Given this list of marker genes AZIN1, BICRAL, TDRD6, NHERF2, GRIA4, SNCA, MED27, PURG, KIAA0040 (NCBI Gene Id 9674), CBFB, RFX7, RBBP5, ZNF770, TMEM242, CPEB3, ABI3BP, PCDHB5, C18orf63, CRISP1, RYR2 (NCBI Gene Id 6262), DCUN1D4, PABPC1, CHD6, ODF4, CUL3, PISD, SLC17A6 (NCBI Gene Id 57084), SLC39A10, HSPA8, ARPC5, OMD, PLD1, CMPK1, GRID2, MAN2A1, CLDN23, CADPS, MEF2C, PTH, KLHL1, ADAM10, PCDH10, NDNF, CCAR1, AGTPBP1 (NCBI Gene Id 23287), SPHKAP, ZNF382, CAPZA2, KPNB1, STYX (NCBI Gene Id 730432), CPEB2, TNKS, SOD2, PDE4DIP, MEIS1, CARHSP1, GRK5, HMGB1, FSTL5, KIAA1328, PEX2, OCRL, HIPK1, USP9Y, KCNQ5, DMXL1, PCK1 (NCBI Gene Id 5105), ZSCAN31, UBR1, IGF2BP1, ZNF600, LPAR1, RWDD2A, STX11, CADM2, RAI1, C1orf21, PCDH15, DIP2A, BAALC, EPC2, ZSCAN2, TMEM50B, PRICKLE2, GJA1, MMRN1, CCND2, ACSL6, NOL7, CPSF6, GJB6, CNST (NCBI Gene Id 163882), ZFAND6, KRTAP11-1, ISL1, ZNF281, SEMA3A, EDEM3 (NCBI Gene Id 87240), CCDC43, PFN2, GOLPH3, DAAM1, MCM9, INSYN2A, RBMS3, here is a description of the gene set: from publication Chen Y, Wang X (PMID 31504780) Human Gene Set: MIR106A_3P Genes predicted to be targets of miRBase v22 microRNA hsa-miR-106a-3p in miRDB v6.0 with MirTarget v4 prediction scores > 80 (high confidence targets). studied in species Homo sapiens